The following is a description of a gene set: TNF-NFKB signaling pathway. Pathway ID: N00151. Pathway type: Reference. Pathway class: nt06516 TNF signaling. Pathway Definition from KEGG: TNF -> TNFRSF1A -> (RIPK1+TRADD+TRAF2/5) -> (TAB1/2/3+TAK1) -> IKK -> NFKBIA -> NFKB Human Gene Set: KEGG_MEDICUS_REFERENCE_TNF_NFKB_SIGNALING_PATHWAY species: Homo sapiens, and this is the list of marker genes: MAP3K7, TRADD, TNF (tumor necrosis factor), RIPK1 (NCBI Gene Id 8737), IKBKB, TAB1, NFKBIA, TAB2, IKBKG, TRAF5, TRAF2 (NCBI Gene Id 7186), NFKB1, TNFRSF1A, CHUK, TAB3, RELA